The following is a description of a gene set: studied in species Mus musculus Hepatoblastoma, the most common pediatric liver cancer, is tightly linked to excessive Wnt/beta-catenin signaling. Here, we used microarray analysis to identify two tumor subclasses resembling distinct phases of liver development and a discriminating 16-gene signature. beta-catenin activated different transcriptional programs in the two tumor types, with distinctive expression of hepatic stem/progenitor markers in immature tumors. This highly proliferating subclass was typified by gains of chromosomes 8q and 2p and upregulated Myc signaling. Myc-induced hepatoblastoma-like tumors in mice strikingly resembled the human immature subtype, and Myc downregulation in hepatoblastoma cells impaired tumorigenesis in vivo. Remarkably, the 16-gene signature discriminated invasive and metastatic hepatoblastomas and predicted prognosis with high accuracy. from publication Cairo S, Armengol C, De Reyniès A, Wei Y, Thomas E, Renard CA, Goga A, Balakrishnan A, Semeraro M, Gresh L, Pontoglio M, Strick-Marchand H, Levillayer F, Nouet Y, Rickman D, Gauthier F, Branchereau S, Brugières L, Laithier V, Bouvier R, Boman F, Basso G, Michiels JF, Hofman P, Arbez-Gindre F, Jouan H, Rousselet-Chapeau MC, Berrebi D, Marcellin L, Plenat F, Zachar D, Joubert M, Selves J, Pasquier D, Bioulac-Sage P, Grotzer M, Childs M, Fabre M, Buendia MA (PMID 19061838) Mouse Gene Set: CAIRO_LIVER_DEVELOPMENT_DN Genes down-regulated at early fetal liver stage (embryonic days E11.5 - E12.5) compared to the late fetal liver stage (embryonic days E14.5 - E16.5)., and this is the list of marker genes: Klkb1, Elane, Isg20, Cbs, Alox5ap, Lbp, Mst1, Serpina1c, Cd68, Gcat, Hagh, Col18a1, Bicral, Hpn, Etfa (electron transferring flavoprotein, alpha polypeptide), Serping1, Gstt1, Lpin2, Cd3g, St6gal1, Cyp27a1, Sstr2, Hgfac, Tmprss2, Igfbp1, Camp, Cfp, H2-Aa, Dhrs7, Adgre1, Slc7a7, Orai3, Pcsk7 (NCBI Gene Id 18554), Gcdh, Crot, Lcat, Mtarc1, Hsd17b2, Gstm5, H2-T23, Itih3, Ngly1, Pink1, Aldh3a2, Ebp, Gjb1 (gap junction protein, beta 1), Sqor, Tacc1, Pygl (liver glycogen phosphorylase), Afm (afamin), Sema4g, Aldh1b1, Haao, Bdh1, Lcp1, Fga, Abca7, F11, Aqp9, Qprt, Matn2, Acadm, Ccr2, Car5a, Tst, Slc16a2, Entpd5, Anxa1, Rida, Psap, Marchf5, Gldc, Ambp, Ech1, S100a8 (NCBI Gene Id 99591), Clpx, Vtn, Maob, Itih4, Tac2, Lgals9, Hp, Herc1, Grik1, Apob, Slc38a3, Fryl, Phyh, Ncaph2, Kntc1, Cfh, Ctsh, Slc2a4, Cdh1, Fgb, Rad52 (NCBI Gene Id 19365), Fgg, F2, Il1rn, Agt, Slc37a4, Mpo, Morc4, Angptl3, Cps1, C1qa, Nabp1 (NCBI Gene Id 98468), Pglyrp1, Amy1, Serpind1, Dpys, Cybb (NCBI Gene Id 97621), Bhmt, C9, Nrn1, Slc44a4, Plg, Gpld1, Selenbp1 (NCBI Gene Id 229585), Cd302, Gnmt, Crp, Gsn, Lcn2, Upk1b, Pck2, Asgr2, Zfp523, Kif13b, Apof, Ndrg1, Dhcr24, Slc30a9, F10, Fmo1, Cyp2f2 (NCBI Gene Id 13107), Gc, A2m, S100a9, Ces1d, Slc39a4, Grik5, Lipc, Itih2, Pdia5, Cldn1, Lyz2, Tapbp, Saa4, Apoe, Serpinf1, Nid1, Ovol1, Pla1a, Tent5a, Sp4, Pcyt2, Itih1 (NCBI Gene Id 16424), H6pd, Serpinc1, Fn1, Ddx27, Prg2, Ltf, Pgm1, Gamt, Oprm1, Slc27a5, B3gnt3, Plac8, Ttpa, Abca8b, Brca1, Abcc6, C3, Lrp1, Pon3, Fah, Aqp1, Hmox1, Prtn3, Ctns, Cpb2, Rdh5, Pkn2, Ppara, Arg1, Pipox, Tnfrsf11a, Kng1, Hmgcs2, Spp2, Cyld, Jak2, Serpina10, Hmgcs1, Nsdhl, Serpinf2, Pde8a, Dcxr, Kdelr3, Gm2a, Smpdl3a, Tmem30b, Lyst, Olfm4, Acaa2, Cpq, Tfr2, Stab2, Csad, F12, Spag5, Man2a1, Proc, Acsl1, Fkbp11, C8a, Hc, C8g, Rbm14, Ahsg, Gstt2, Aldh1l1, Gstm1